The following is a description of a gene set: species: Homo sapiens Human Gene Set: GOBP_REGULATION_OF_MEMBRANE_TUBULATION Any process that modulates the frequency, rate or extent of membrane tubulation., and this is the list of marker genes: SH3GLB1, ASAP1, DNM2, WASL (NCBI Gene Id 8976, WASP like actin nucleation promoting factor), ATP10A